Given this list of marker genes NPAS3, ABCC1, PIK3CG, KCNQ4, CMKLR1 (chemerin chemokine-like receptor 1), FNDC3A, FAM168A, FGF11, FSHR, RTL8B, PARVA, SHISA7, PLEKHG3, TMTC2, WDFY1, KLF14, HDHD2, FRAT2, KLF3, VLDLR, BAHD1 (NCBI Gene Id 22893), SDK2, LDOC1, LRRTM1, H6PD, KCNH1, RFT1, B4GALT1, TMEM178B, ADAM29, EPHX2, NHS (NCBI Gene Id 907), UBXN10, TIRAP, MOB3C, EFNA3, RNASE13, ZNF544, ABTB3, ATXN1, PRX, DNM1L, CTXN2, NINJ1, BRPF3, RIMS4, XIRP1, MTR, KLK5, CEP85, GPD2, SLC23A2, CHL1, SYS1, TNR, CMTM8, GGT7, SLC27A4, STK35, TOMM40L, CERS6, SLC38A2, MTCL2, SLC5A3, MMP24, PPP1R3F, ELK1, ZNF577, UBE2W, VPS39, RALGPS2, SSBP4, GRIPAP1, PTBP1, NDUFAF4, CACNA1E, SAMD12, ETS1, AMOTL1, TPBGL, MDM1, YBEY, GLOD5, ODR4, PLEKHM3, MTMR8, POLR2J3, FBXO21, ZZEF1, SAMD4B, ANKFY1, PALM, BTNL8, GAB1 (GRB2 associated binding protein 1), ZNF423, ZNF322, PPIL1, NLK, TRABD2B, OTP, PRKCB, RAB3IP, MEGF6, PCNX1, PIP5K1C, EPHB3, TSPAN18, ITGA5, IGF2BP1, ARC, ALAD, PIP4K2C, LETM2, EPB41L1, GDAP2, TOMM34, OXSR1, MAML3, ATP6V1G2, LARP1, EMC8, PPP4R1, NFATC2, VCF2, METAP1, MAGI3 (NCBI Gene Id 57725), GPI, KCNIP2, MRAS, CHRM1 (cholinergic receptor muscarinic 1), here is a description of the gene set: species: Homo sapiens Genes predicted to be targets of miRBase v22 microRNA hsa-miR-326 in miRDB v6.0 with MirTarget v4 prediction scores > 80 (high confidence targets). from publication Chen Y, Wang X (PMID 31504780) Human Gene Set: MIR326